The following is a description of a gene set: Mouse Gene Set: GOBP_ANATOMICAL_STRUCTURE_ARRANGEMENT The process that gives rise to the configuration of the constituent parts of an anatomical structure. This process pertains to the physical shaping of a rudimentary structure. Anatomical structures can be macroscopic such as a carpel, or microscopic such as an acrosome. studied in species Mus musculus, and this is the list of marker genes: Sema3f, Bmpr1a, Nrp1 (NCBI Gene Id 270112), Plxna3, Dmd, Hoxb1, Dab1, Dll1, Sema3a, Pax2 (paired box 2), Pantr2, Hspa5 (NCBI Gene Id 99198), Hoxa1, Kcna2, Tfap2a, Kif14, Nrp2, Hoxb2, Plxna4, Egr2, Usp9x, Rac1 (NCBI Gene Id 52352)